The following is a description of a gene set: The somatic process that results in the generation of sequence diversity of T cell receptor genes. studied in species Mus musculus Mouse Gene Set: GOBP_SOMATIC_DIVERSIFICATION_OF_T_CELL_RECEPTOR_GENES, and this is the list of marker genes: Lef1, Lig4, Bcl11b, Tcf7, Prkdc